The following is a description of a gene set: Mouse Gene Set: GOBP_POSITIVE_REGULATION_OF_SECRETION species: Mus musculus Any process that activates or increases the frequency, rate or extent of the controlled release of a substance from a cell or a tissue., and this is the list of marker genes: Cdk5r2, Cadps, Cckbr, Rab27a, Kif5b, Gpr158, Tnfsf11, Tlr4, Sphk2, Cyp4a10, Il13, Ppid, Wls, Crhr2, Anxa7 (annexin A7), Abat, Rab2b, Bmp6, Prl3d2, C1qtnf3, Ang5, Blk, Rab3a, Sstr4 (NCBI Gene Id 20608), Ang6, Npr3, Sybu, Nmu, Prl7b1, Pard6a (par-6 family cell polarity regulator alpha), Hgs, Ppia, Slc12a2, Prl4a1, Rbp4, Cxcl12, Glud1, Tac1, Gab2, Lypd11, Ecrg4, Abcg1, Lypd10, Tgfb1, Slc2a2 (solute carrier family 2 (facilitated glucose transporter), member 2), Or51e2, Avpr1b, Cpb2, Stxbp5, Bsg, Myo5b, Jak2, Aacs, Ins1, Il1a, Ap1g1, Vps4b, Nppc, Vps35, Egfr, Ptbp1, Il1b, Lamp1, Gna11, Prkcb, Prl7a2, Bcl2l1, Pfkm, Map1lc3b, Pla2g4a, Dynll1, Trh, Ptafr, Edn3, Ang, Prl2c2, Tfr2, Ffar1, Camk2n1, Kmo, Prl2b1, Ppard, Ttn, Prkaca, Nmb, Inhbb, Rph3al, Bad, Ncoa6, Snca, Tunar, Syk, Ncs1, Prl3a1, Ang4, Sirt3, Rab34, Cyp2j5, Smad4, Grik1, Slc6a1, Plcb1, Runx1, Isl1, Trpm2, Nlgn2, Myh9, Adora2a, Prkce, Rab3gap1, Prl8a1, Clasp1, Gja1, Zfp384, Trpa1, Rab3d, Sox11, Serp1, Prl7a1, Agt, Exoc2, Crhr1, Prl3c1, Rapgef4, P2ry1 (NCBI Gene Id 18441), Tmf1, Apbb1, P2rx7, Ep300, Baiap3, Ptpn23, C1qtnf12, Prl8a6, Cacna1c, Sirt1, Ghrh, Prl5a1, Stxbp1, Fgg, Gabbr1, Bglap2, Pcsk1, Stam, Prl3b1, Negr1, Fto, Mfn2, Spp1, Rab9, Myb (NCBI Gene Id 97674), Exph5, Edn2, Cd2ap, Cdk5, Pcp4, Chrm3, Hif1a, Pdcd6ip, Adora3, Tnfrsf11a, Sytl2, Gipr, Stxbp2, Sct, Pdx1, Tacr2, Rab27b, Gpr39, Apln, Cacna1b (calcium channel, voltage-dependent, N type, alpha 1B subunit), Rab7, Cask, Gcg, Cacna1d, Syt4, Edn1, Prl3d3, Nkx6-1, Syt7, Oxt, Vdr, Nr1h2, Mmp13, Rab8b, Prl2c1, Bmp2, S100a9, Ang2, C1qtnf1 (C1q and tumor necrosis factor related protein 1), Cyp4a32, Smpd3, Cacna1h, F2rl2, Golph3l, Prkca, Tardbp, Ucn3, Zp3, Trpm4, Glp1r, Fcer1a, Nucb2, Pla2g10, Mpc2, Htr2c, Ildr1, Acvr2a, Nkx3-1, Adcyap1 (adenylate cyclase activating polypeptide 1), Cadps2, Cartpt, Cyp4a31, Prl7d1, Cck, Trem2, Sdc4, Snap25, Xbp1, Oga (O-GlcNAcase), Myrip, Prkar1a, Myh10, Sec24a, Tgfb3, Chrnb2, Cd160, Myom1, Slc6a4, Glul, Ghrl, Ppp3ca, Mcu, Il4ra, Unc13a, Pfkfb2, Lrrc8a, Prl2c3, Gal, Stx1b, Prl6a1, Prkn, Tacr1, Dab2, Rgcc, Hcar2, A1cf, Gpld1, F2, Kiss1, Slc18a3, Stx1a, Adcy8, Unc13d, Vps4a, Alox12b, Prl8a9, Ptger4, Dnm1l, Rab15, Cacna1g (calcium channel, voltage-dependent, T type, alpha 1G subunit), Irs2, Igf1, Oxtr, Syt1, Septin5, Tgfb2, Pla2g6, Snf8, Gnaq, Selenot, Fgb, Cntf, Prl2a1, Aimp1, Ptpn11, Prl7c1, Avp, Pex5l, Gip, Prl8a8, Osbp, Map2k6, Arf6, Acsl4, Sirt6, Nadk, Itsn1, Vamp8, Cyp27b1, Grin2b, Malrd1, Itgb2l, Ffar2, Pink1, Gck (glucokinase), Nr3c1, Tmed10-ps, Nell2, Rac1 (Rac family small GTPase 1), Arf1, S100a8, Ptges, Gpr68, Syt10, Prl8a2, Hfe, Doc2g, Atg7, Itpr1, Stim1, Adora1, Tcf7l2, Capn10, Trpc1, Mif (macrophage migration inhibitory factor (glycosylation-inhibiting factor)), Doc2b, Myo18a, Ucn, Lepr, Rtn4, Pck2, Itgb2, Casr (NCBI Gene Id 12374), Stx4a, Foxl2, Sphk1, Il4, Lif, Pld2, Ier3ip1, Gpr27, Sytl4, Grk2, Fgfr4, Vegfc, Rufy4, Galr1, Arrb1, Fgfr1, F2rl1, Nnat, Lrp1, Psmd9, Kcnn4, P2ry2, C2cd2l, Sdc1, Syt9, Gper1, Ano1, Adora2b (NCBI Gene Id 632506), Mlxipl, Rfx6, Gata1, Itgam (integrin alpha M), Drd2, Dpysl2, Cd177, Hrh3, Tac4, Cyp19a1, Vsnl1, Npy2r, Retn, Gata2, Abcb11, Doc2a, Oxct1, Clcf1, Prl3d1, Pla2r1, Tsg101, Micu3, Orai1, Chmp2a, Grp, Prl2c5, Rab5a, Aqp1, Rph3a, Ms4a2, Kcnb1 (NCBI Gene Id 16500), Avpr1a, Hnf1a, Apbb3, Atg5, Gnas, Prkd1, Abcc8, Nppa, Slc18a1, Clasp2, Cd38, Ffar4, Oprk1, Nr1h4, Nr0b2, Slc4a8, Ntsr1, Fga, Bglap, Adam9, Rhbdd1, Tm7sf3, Pparg, Fcer1g, Sdcbp, Tlr2, Hyal3, Mapk9, Arhgef7, Kiss1r, Fgr, Crh, Irs1, Tmed10, Prl, Tmem132a, Plcd1, Sox4, Lgals3, Cckar, Creb1, Ghrhr (growth hormone releasing hormone receptor), Pla2g3, Cyba, Nlgn1 (neuroligin 1), S100a10, Atp13a2, Cftr, Dtnbp1, Rasl10b, Cacna1i, Gprc6a, Anxa2, Golph3, Scamp5, Snx4, Unc13b, Ankrd1, Lep, Frmd4a, Htr6, Prkcq, Acsl3, Ins2, Trpm5, Hcfc1, Ppp3cb, Slc30a8